Given this list of marker genes Nodal, Hpgds, Zp1, Pdik1l, Rad1, Wnt5a, Insl6, Ube2b, Calr, Igf1, Eppin, Wdr77, Fbxo43, Apc (APC, WNT signaling pathway regulator), Zwint, Zfpm2, Arhgdib, Elf5, Acvr1c, Nr5a1, Npr2 (natriuretic peptide receptor 2), Ddb1, Ptgds, Trpc2, Ybx3, Hormad1, Zp2, Ovgp1, Rgn, Sycp2, Dmrt1, Grb14 (NCBI Gene Id 99012), Gpr149, Lif, Prkaca, Stk11, Myh9, Nkx3-1, Serpinf1, Nlrp5, Eaf2, Stk35, Cdkn1b, Mos, Ttk, Kit, Snai1, Timp1, Sulf1 (NCBI Gene Id 98668), Bcl2l1, Ada, Wfdc6a, Knl1, Zp3, Mael, Chfr, Il1a, Trip13, Prdx4, Wee2, Asmt, Tex11, Nanos2, Fbxo5, Rps6ka2, Pkmyt1, Dusp1, Bmp4, Wt1 (WT1 transcription factor), Ovol1, Prkacb, Ptgdr2, Shb, Astl, Adam24, Spinkl, Spink13, Bmp7, Osm, Wfdc6b, Tpst2, Plat, Nppc, Zfy2, Gja1, Esp22, Sod1, Wnt4, here is a description of the gene set: Any process that stops, prevents, or reduces the frequency, rate or extent of reproductive process. Mouse Gene Set: GOBP_NEGATIVE_REGULATION_OF_REPRODUCTIVE_PROCESS studied in species Mus musculus